Given this list of marker genes KIF28P, MYO9A, KIF13B, KIF4B, KIF21A, MYH6, KIF18A, STARD9, SMC3, MYO1F, KIF1A (kinesin family member 1A), MYH1, DNAH11, DNAH6, KIF13A, PIN1 (peptidylprolyl cis/trans isomerase, NIMA-interacting 1), KIF17, MYO1A, MYO16, KIF20A, KIFC3, KIF27, MYO5C, KIF5C, MYL6B, KIF3B, DNAL4, KIF21B, MYL3, DNAI2, MYH2, MYH13, DYNC1I2, KIF20B, MYO1B (myosin IB), MYO5B, KIF2C, KIF6, MYH15, KIF9, DNAH1, DNAH7, DNAH9, KIF7, MYO1D, KIF2B, MYO1H, MYO6, MYO7B, DNAH17, KIF11, ACTC1, MYO1C, MYH7, MYO3B, KIF2A, MYH7B, KIF16B, KIF24, MYH3, MYL6, KIF12, KIF26B (NCBI Gene Id 55083), DNAH3, CENPE, KIF3A, MYO15A, DNAH14, DYNLRB1, KIF1C, DNAH10, KIFC2, KLC1, MYH9, MYH4, DNAI1, MYO1E (NCBI Gene Id 4643), MYO3A, DYNC2H1, DNHD1 (dynein heavy chain domain 1), MYO9B, MYO5A, KIF22, DYNC1H1, GPR88, TNNT2, KIF18B, MYO19, MYO18B, KIF3C, KIF19, KIF14, APPBP2, KIF26A, MYH14, MYO1G, KIF5B (NCBI Gene Id 3830), KIFC1, DYNC1I1, DNAH2, KIF23, DNAH12, DYNLRB2, MYO10, KIF15, MYH10, KIF4A, DNAH8, MYH11, KIF5A, MYH8, DNAH5, KIF1B, KIF25 (NCBI Gene Id 3834), MYO7A, here is a description of the gene set: species: Homo sapiens Human Gene Set: GOMF_CYTOSKELETAL_MOTOR_ACTIVITY Generation of force resulting in movement, for example along a microfilament or microtubule, or in torque resulting in membrane scission or rotation of a flagellum. The energy required is obtained either from the hydrolysis of a nucleoside triphosphate or by an electrochemical proton gradient (proton-motive force).